The following is a description of a gene set: species: Homo sapiens The series of molecular signals mediated by the detection of carbohydrate. Human Gene Set: GOBP_CARBOHYDRATE_MEDIATED_SIGNALING, and this is the list of marker genes: CLEC7A, SMARCA4, COLEC12, AGER, PIH1D1, PDX1, UBTF, NKX6-1, SMARCB1, MLXIPL, USF1, USF2, ADCY8